The following is a description of a gene set: Genes negatively differentially expressed in cell type: CD4+ T cell upon treatment with cytokine: IL-3 in mouse lymph nodes in vivo. from publication Cui A, Huang T, Li S, Ma A, Pérez JL, Sander C, Keskin DB, Wu CJ, Fraenkel E, Hacohen N (PMID 38057668) Cytokines mediate cell-cell communication in the immune system and represent important therapeutic targets. A myriad of studies have highlighted their central role in immune function, yet we lack a global view of the cellular responses of each immune cell type to each cytokine. To address this gap, the authors created the Immune Dictionary, a compendium of single-cell transcriptomic profiles of more than 17 immune cell types in response to each of 86 cytokines (>1,400 cytokine-cell type combinations) in mouse lymph nodes in vivo. A cytokine-centric view of the dictionary revealed that most cytokines induce highly cell-type-specific responses. For example, the inflammatory cytokine interleukin-1β induces distinct gene programmes in almost every cell type. A cell-type-centric view of the dictionary identified more than 66 cytokine-driven cellular polarization states across immune cell types, including previously uncharacterized states such as an interleukin-18-induced polyfunctional natural killer cell state. species: Mus musculus Mouse Gene Set: CUI_T_CELL_CD4_IL3_RESPONSE_DN, and this is the list of marker genes: Hspa1a, Tsc22d3, Zfp36l2, Fos, Jun, Hspa1b, Klf6, Uba52, Btg2, Junb